The following is a description of a gene set: Human Gene Set: GOMF_ACYLTRANSFERASE_ACTIVITY species: Homo sapiens Catalysis of the transfer of an acyl group from one compound (donor) to another (acceptor)., and this is the list of marker genes: NSMCE2, CIITA, TRIM72 (NCBI Gene Id 493829), ZDHHC15, FBXL3, KAT2B, SERINC2, SPTLC1, RBX1, RNF121, BAAT, ZDHHC16, TGM5, TRIM55 (tripartite motif containing 55), SPTLC3, RBCK1, CPT1C, FNTA, RNF166, RC3H2, RNF19A, MGRN1, CDKN2A, UBE2T, NOSIP, SH3RF3, ELP3, UBE2N, RNF228, VHL, GGT5, TRIM11, ELOVL7, MED31, RCHY1, RPL37, GGT3P (NCBI Gene Id 440802), FBXO44, UBE2S, ATAT1, PELI3, STUB1, PPIL2, TRIM21, RNF148, FBXO9, HHAT, TRIP12, DGAT1, MED21, ACSM6, MYLIP, TGM2, RNF144A, ARK2N, TGM1, SPTSSA, TRIM13, NAT1, SIRT1, SIRT4, RPL11, UBR2, PEX10, WDSUB1, GCAT, AWAT2, NEDD4L, MAEA, FBXO30, CDY1, CLOCK, NCOA1, RNF182, PPP1R11, VPS18, RNF126, SIAH2, LRSAM1, MALT1, LNX2, TRIM2, HERC4, TRIM35, AWAT1, PML, UBE3C (NCBI Gene Id 9690), RNF152, TRIM49C, KAT6B, BIRC3, TRIM45, TRIM50, UBE2K, MED8, TRIM22, NMT2, RLIM, ZDHHC1 (zinc finger DHHC-type containing 1), ACSM4, AANAT, NAA30, TADA2A, GPAM, QPCT, PIAS1, TRIB3, UBE2QL1, FBXO22, HECW1, TRIM74, CHFR, GNPAT, ZNRF4, NAT14 (N-acetyltransferase 14 (putative)), HECW2, GGT7, HADHA, RNF138, BMI1, GLYATL2, RNF185, RC3H1, CASD1, ACSM5, CBLB, SIRT3, UFC1, PNPLA4, PJA2 (praja ring finger ubiquitin ligase 2), MBOAT2, CRLS1, TRIM39, TRIM49D2, HMGCS1, ELOVL6, OXSM, RPGR, ZDHHC20, ESCO1, RNF122 (ring finger protein 122), NAP1L2, ARIH1, TGM7, DGAT2, MSL2, LIMK1, CERS5, PRPF19, BIRC2, FBXO27, CHAT, DTX4, HERC2, PDZRN3, TRIM64B, TRIM40, RNF114, RABGEF1, GGT6, PIAS4, PORCN, TRAIP, RNF125, CERS2, NAA11, RMND5A, ZDHHC11, TRIM38, MED30, SH3RF1, PLAAT3, ZMIZ2, BRPF3 (bromodomain and PHD finger containing 3), PCGF5, RPS7, LTN1, UBE2D2, NEURL1B, NAT8L, BLOC1S1, RNF144B, PLAAT2, ABHD5, OSGEPL1, RNF8, TRIM61, GID4, AGPAT5, NAA15, TRIM51, GTF3C4, CS, TNFAIP3, EPB42 (erythrocyte membrane protein band 4.2), FANCL, RNF128, CBLL2, ATG5, TRIM28, FBXL22, NAA25, RNF13, TRIM52, RNF225, LNX1, SOAT1, SPHK1, CDC20, UBR1, TNFAIP1, IFNB1, HADHB, UBE2Z, ING3, LCAT, RANBP2, BFAR, ASB1, TAF10, BIRC7, TRIM14, AGPAT2, TRIM44, SMURF1, SCP2, MED7, ARK2C, FBXO3, RNF103, ZDHHC4, UBE2W, TRIM24 (NCBI Gene Id 8805), TGM6, CDC42, TAF1L, RNF38, CNOT4, ASPG, PAFAH1B2, TRIM41, RNF180, RNF216, MBOAT4, GGT1, APOA5, MKRN2, UBE2H, HTRA2, UBE2J1, RNF150, RNF168, TRIM37, MBOAT7, PCGF3, ABHD14B, DTL, NAT10 (N-acetyltransferase 10), UHRF2, CUL9, PTEN, TRIM43, MIB2, ATF2, NEURL1, RNF14, RFPL3, KCMF1, ATG3, ELOVL4, ACAT1, UBE2F, HECTD2, USP22, RNF40, UBE2NL, RAD18, TRIM6, NMT1, MKRN1, ATG10, UHRF1, BIRC6, MARCHF5, LPCAT1, CPT2, NEURL4, PELI2, RFPL2, ZFP91, PNPLA3, RNF135, RNF20, HDAC4, BRCA2, LPGAT1, SERINC1, ZDHHC22, RNF4, TRAF2, TRAF3IP2, ZDHHC14, TRIM68, VPS11, TRIM33 (NCBI Gene Id 80027), ABHD8, RNF115, HACE1 (NCBI Gene Id 57531), ESCO2, LRAT, MOGAT2, FNTB, PLA2G4C, RNF34, RNF113A, UFL1, DLAT, RNF208, ZDHHC19, ZNF451, PLAAT5, TAFAZZIN, TRIM58, PELI1, BCAS3, PJA1 (NCBI Gene Id 64219), TRIM56, NEURL2, TRIM77, GLYATL3, CUL5, ZDHHC2, SPTSSB, SIRT6, SATL1, MEAF6, ANAPC11, AREL1 (apoptosis resistant E3 ubiquitin protein ligase 1), APOA1, TRIM49, DTX2, UBE2V1 (NCBI Gene Id 7335), PIAS2, BTRC, BRD1, TRAF7, DTX3L, TGM3, RFFL, RNF139, FBXO10, RNF25, ZSWIM2, SMARCE1, TRIM27 (NCBI Gene Id 5987), RNF223, PRDX6, NAGS, ZDHHC6 (NCBI Gene Id 64429), TOPORS, NAA20, PHF10, UBE2M (NCBI Gene Id 9040), TRIM47, CDKN1B, RNF212B, ABHD4, AMFR, CCNB1IP1, RNF149, MKRN3, MCAT, TRAF3, MED27 (NCBI Gene Id 9442), MED11, HAT1, TRIM32, UBE2A, FBXO40, ARIH2, RNF11, RMND5B, GLYATL1, SIAH3 (NCBI Gene Id 283514), MARCHF9, RAG1, PLA2G4A, LONRF2, SPTLC2, KLHL20, RFPL4AL1, ITCH, RNF220, NFX1, EGR2, ALAS2, SOAT2, SIAH1, LPCAT2, TRIM36, JADE1, CPT1B, ACAA2, DZIP3, ENTREP1, RFPL4A, NCCRP1, WWP1, SYVN1, NEDD4, MARCHF8, ZNF738, ATG16L1, TRIM49B, CDC23, UBR3, ZDHHC13, FBXO4, RNF170, CBLL1, MARCHF7, KAT14, UBE2E1, LCLAT1, TRIML1, DLST (NCBI Gene Id 1743), MED12, TRIM15, WWP2, UBE2D1, UBE2L5, TRIM34, ELOVL2, RNF141, ZBED1, APOC1, CUL4A, PEX2, HUWE1, RNFT2, CBL, TRAF6, CERS1, TRIM25, UBE2G2, FBXO17, ATE1, NAT8, TRIM59, HLTF, PNPLA1, HGSNAT, YKT6 (YKT6 v-SNARE homolog), FBXO11, UBE2D3, MCM3AP, KLHL9, KAT7, JADE2, NHLRC1, RNF227, FBXO2, FASN (NCBI Gene Id 2194), TRIM5 (NCBI Gene Id 85363), KCTD10, FBXO21, CREBBP, AGPAT4, TRIM63, RFPL1, RNF31, UBR4 (ubiquitin protein ligase E3 component n-recognin 4), MIB1, KMT2C, FBXL21P, BRCA1, UBE2U, GCN1, NT5C2, KLHL42, PAFAH1B3, AGPAT1, TLCD3B, MDM4, LPCAT4, TRIM8, HERC5, RSPRY1, ELOVL5, HERC2P3, PDCD5, SAT1, BAZ1A, HERC1, RNF167 (NCBI Gene Id 26001), PYGO2 (NCBI Gene Id 90780), AKTIP, PAFAH2, RNF187, ZDHHC17, UBOX5, RNF212, MAGEL2, RNF2, ACSM2A, UBE4B, MARCHF1, GLYAT, PRKN, SMURF2, TRIM64C, WDR24, TRIM51G, TRIM4, SHPRH, UBL4A, FBXL5, QPCTL, CRAT, RNF39, NAA60, FZR1, ANKIB1, MARCHF3 (NCBI Gene Id 153277), NAA16, FBXO5 (F-box protein 5), PNPLA2, RNF157, SIRT7, HERC3, CROT, UBE2L3, BRPF1, RNF5, TRIM42, TRIM71, CDC20B, PLA2G4E, DTX3, TRIM17, RNF146, MARCHF2, ACAT2, NEURL3, ZNF598, IRF2BPL, TRIM49D1, ARRB1, TRIM54, MARCHF11, EP300, BAG5 (BAG cochaperone 5), ZDHHC24, UBE2Q1, ZDHHC23, RNF133, F13A1, RNF175, UBE2D4, RNF213, BCOR, TRIM10, C10orf90, GNPNAT1, TRIM43B, HECTD1, NAA80, GPAT3, GLMN, ACSM1, ING4, ZDHHC11B, RBBP6, UBE2R2, IRF2BP1, SIRT5, TRIM64, BARD1, ASB2, XIAP, SPRY2, FBXO25, DTX1, ACSM3, CBX4, TRIM9, PLAAT4, UBE2E2, KAT5, MED17, KAT2A, RNF41, RNF215, GPAT4, RFWD3, COP1, RPL23, RNF181, MOGAT3, TRIM31, CLYBL, TRIM26, APOA2, RFPL4B, AGPAT3, ZDHHC7, RPS15, UBE3D, CERS3, MED1, RNF111, MBOAT1, RNF123, TAF9, UBE3B, RNF7, NAT16, UBE2G1, APOE, ZDHHC18, PARK7, ACSM2B, PLA2G15, SHARPIN, RNF145 (NCBI Gene Id 353159), UBR7, UBE2B, TRIM75, FBXO7, PEX12, TTC3, CDY2B, ZMIZ1, ZNRF3, CERS4, ZDHHC5, FBXO6, UBE2Q2, RNF19B, KAT8, ZDHHC21, FBXW2, MARCHF6, RNF43, KAT6A, ATG12, DBT, RING1, TRIM62, SH3GLB1, ZDHHC3, CUL3, OBI1, HECTD3, SIRT2, CDY1B, RNF10, RNFT1, MOGAT1 (NCBI Gene Id 116255), OSGEP, TRIB2, TRIM48, TRIM7, UBE4A, KLHL13, PIAS3, TRIML2, CPT1A, TGM4, ZDHHC12, RNF6 (NCBI Gene Id 6049), NAA40, ACLY, PIN1, CDY2A, WSB1, ANAPC4, RNF130, CUL2, UBE2J2, KIAA1586, UBE2O, PLAAT1, TRAF5, MDM2, SRCAP, FBXL14, RNF214, MED6, RNF26, RNF112, DDB2, TRIM73, NUPR1, NAA50, KCTD13, FBXL6, SH3RF2, TRIM3, NSMCE1, UBA3, GLUL, MEFV, G2E3, BIRC8, PIGW, HMGCS2, NAT8B, FBXW7, ELOVL3, RNF169, CCAR1, TMEM129, DGAT2L6, CLN5, HERC6, ASB4, UBE2E3, ASB12, MED10, CBX8, NHLRC3 (NHL repeat containing 3), MYCBP2, GPAT2, TRIM65, OTUB1, TMEM68, RNF183, DCST1, SAT2, ACAA1, GLYATL1B (glycine-N-acyltransferase like 1B), ALAS1, MARCHF4, APOA4, CERS6, LPCAT3, LIPT1, SUMO2, UBE2I (NCBI Gene Id 7329), PDHX, ZNRF1, TRIM60, NAT2, MEX3C, BSPRY, NAT9, KLHL21, RPL5, RNF186, ZDHHC9, UBR5, ARHGAP5-AS1, UBE2C, LMO7, UBA7, RNF217, FBXO24, BRAP (NCBI Gene Id 8315), HECTD4, CDC34, NAA10, TRIM69, ELOVL1, NCOA3, TRIB1, RNF44, MUL1, UBE2L6, TRIM23, LIPT2, HDAC7, RPS20, ZDHHC8 (NCBI Gene Id 29801), CBLC, UBE3A, TAF1, ZNRF2, GTF2B